The following is a description of a gene set: studied in species Homo sapiens from publication Chen Y, Wang X (PMID 31504780) Human Gene Set: MIR7152_5P Genes predicted to be targets of miRBase v22 microRNA hsa-miR-7152-5p in miRDB v6.0 with MirTarget v4 prediction scores > 80 (high confidence targets)., and this is the list of marker genes: FAHD1, MTERF4, SMURF2, PIP4P2, KDM2A, ANKMY2, CLCN3, IDS, GNL1, ZC3HAV1, SNX10, ZNF101, SCNM1, TGFB2, SMIM10L1, PHACTR3, DCLK1, SV2C, BLTP3A, FYCO1, ETV1, EPHA8 (EPH receptor A8), DIP2B (disco interacting protein 2 homolog B), APOO, VCPIP1, PALS2, IL6ST, KCTD16, SLC7A11, PHIP, MAP1B, DNMT3A, PPP2R2B, ZNF345, LCORL, ZNF329, PLEKHA6, LPAR4, SMG1, CIT, KIF2B, SLC12A2, AMBN, TENT5A, APOL6, BACH2, NACA, GRIA2, ZC3H10, KDM4C, HERPUD1, BACE2, RAP2A, CSRNP3, ZFP82, FCGR3A, NRG1, PELI1, DLC1, TMEM154, FAM86C1P (NCBI Gene Id 90960), CNOT6L, SLC26A11, TRIB2, SIKE1, TNFSF13B, NR2F1, BHMT2, EIF4E, CNR1, SLC24A2, RABL2A (NCBI Gene Id 11159), FNIP1, KLHL1, SOCS3, ENTREP1, RREB1, RABL2B (NCBI Gene Id 11158), UBE4A, ATAT1, RNF19A, CASP2, COA5, RASSF6, NIPBL, ATP11A, UPF1, MMRN1, BHLHE22, VAPA, TNKS2, KCNJ15, ELFN2, DMRTA1, NRG3, SRSF3, GGCT, BCAN, TTC21B, SLAIN1, ACTR3, NF1, KCNMA1, MLLT3, ATP6V1G3, KDM6A, PTGR3, FECH, IRS1 (insulin receptor substrate 1), NCOA1, NUDT21, RNF146, DUSP16, SPTSSA, CRB1, ZNF618, RFX3, CDK14, PTPN4, CUX1, PLXNA4, GDNF, LYPD6, CCDC47, ZNF615, HOOK3, USP36, CREG2, COMMD8, SOX12, LCOR, TXLNB, TMEM178B, KPNA1, YWHAB, EBP, CBX6, LHFPL3, RELN, CAMK4, PDSS2, CADM1, DGKE, IQCJ, USP10, CCKBR, ZNF100, CDK4, NETO1, MID1, CYBC1, TENM1, UBXN2B, ZNF704, MAPK6, TDRKH, CD93, KLF9, EPHB1, SWAP70, TMPRSS15, NEFH, ZBTB20, TMEM45B, MARCHF6, DDX3X, SLC22A10, ANKRD44, ZCCHC7, SLC35E2A (solute carrier family 35 member E2A (pseudogene)), GRIA4, TNRC6B, WDCP, APPBP2, DPY19L2, WDR31, DCX, ARHGAP36, ZNF561, SLC25A33, BICD2, ADH1B, PCDH20, CUL3, STXBP5, NDUFA4, SIAH1, GABBR2, ADRA1A, CTDSPL2, ESRRB, RBM48, SARM1, ZWINT, CACNB2, NLGN1, HOXB9, ZNF596, R3HDM1, CASP7, EPB41L1, EOGT, SIX4, LETM2, ITPRIP, VANGL1, YOD1, LINGO4, ONECUT2, PLAGL1, COMMD3-BMI1, PLCB4, MTMR7, POU3F2, FMOD, PRPF40A, RBM41, SH3PXD2A, TET2, MTX3 (NCBI Gene Id 345778), THBS2, DKK2, CABLES1, GPR156, HNRNPA3, CLCF1, ZNF331, ZNF418, GSTO2, AHCYL1, ARHGAP5, OLFM4, NSG2, GRIN2A, ENTPD4, MACROD2, CNGB1, SEC22B, SLC49A4, PTPRB, FOXA2, ITGA10, MYSM1, HDX, WWTR1, TAF4B, TNIP3, KIAA1549L, RICTOR, KLHL13, KIAA0513